The following is a description of a gene set: Human Gene Set: GSE6259_33D1_POS_VS_DEC205_POS_FLT3L_INDUCED_SPLENIC_DC_DN Dendritic cells (DCs) process and present self and foreign antigens to induce tolerance or immunity. In vitro models suggest that induction of immunity is controlled by regulating the presentation of antigen, but little is known about how DCs control antigen presentation in vivo. To examine antigen processing and presentation in vivo we specifically targeted antigens to the two major subsets of DCs using chimeric monoclonal antibodies. Unlike CD8+ DCs that express the cell surface protein CD205, CD8- DCs, which are positive for the 33D1 antigen, are specialized for presentation on MHC class II. This difference in antigen processing is intrinsic to the DC subsets and associated with increased expression of proteins associated with MHC processing. Genes down-regulated in spleen dendritic cells from Flt3L Melanom injected mice: 33D1+ versus DEC205+ subpopulations. from publication Dudziak D, Kamphorst AO, Heidkamp GF, Buchholz VR, Trumpfheller C, Yamazaki S, Cheong C, Liu K, Lee HW, Park CG, Steinman RM, Nussenzweig MC (PMID 17204652) studied in species Homo sapiens, and this is the list of marker genes: DPCD, CYRIA, ARHGAP9, TBC1D19, RAB9A, KMT5C, SLC29A3, SERTAD3, ABCD1, GGA2, CD93, HHEX, P2RX4, PLD2, ITPRID2, NUMA1, DNAAF5 (dynein axonemal assembly factor 5), SIDT2, PMS1, KCNK13, TMEM51, SULF2, TUBB2B, KCNJ10, INSR, ATF6, NSDHL, PRCP, H1-2, HAUS6, ELMOD2, RPL10A, NSMAF, CELF2, TMEM26, ECT2, PDIA3, ZFYVE26, AAAS, WLS, ADAP1, STAT1, PLXDC1, MPRIP, TBC1D8, ARHGAP25, UBQLN2, MAVS, BTBD2, TCEAL1, PYGB, GCA, PIK3R1, ABHD12, ISOC1, SCARB2, HEBP1, PLXNB2, NPAS2, LIMA1, SLC16A7, PCYOX1, CALCOCO1, P3H3, CYLD, ADGRE5, PDE4DIP, MS4A14, PACC1, HADH, PIAS1, ABHD4, SLC46A3, BCL2L11, GET3, GTF2I, NCOR2, WDR62, RIPK2, MICAL2, PPP3CB, LRATD2, KATNB1, TUBGCP4, HSD17B4 (hydroxysteroid 17-beta dehydrogenase 4), MAGED1, GALNT2, FRMD4A, NFATC2, PLXNA2, SESN1 (NCBI Gene Id 27244), CPNE8, SCFD2, TGS1, BAMBI, TMEM131, PRKCH, CXCR4, AKR1B10, IFT74, TMEM64, CDK19, NDRG3, ATP13A2, ADAP2, RASA3, MDH1, ATXN1, LANCL1, GPR162 (NCBI Gene Id 553113), SLC29A1, TMEM141, RRM1, PLEKHM1, TMEM147, OTUD1, PTGER4, IL6ST, NIPSNAP1, GPR65, GALC, NEURL3, INPP5D, DEXI, CHD3, HDAC6, BPNT1, CLPB, RNLS, CASTOR2, B3GALNT1, PCCB, ZC4H2, SLC35C2, CFAP251, VAC14, TOR3A, NEK7, PCP4L1, TCF7L2, LAT2, DHCR7, TLR6, MSMO1, ANKLE2, IDE, FADS1, CDIN1, ARL6, ELMO2, NEDD4L, SLC45A4, DAG1, ARHGAP19, CLIC5, ENTREP3, ETV5, CALHM2, GUSB, SLC25A35 (solute carrier family 25 member 35), CYB5R1, EXT2, MYO1B, LARGE1, BCKDHA, OXR1, CLN6, NUAK1, ASCC1, ALG6, SLC22A5, RNASEL, PCYT1A, TMEM41A, SLC43A2, LIMK1, TGFBI, ATP2B1